Given this list of marker genes FKRP, AHNAK2, UNC5D, PLD3 (NCBI Gene Id 23646), GPR39, CCL1, CTDP1, SLC26A9, GBX2, ADGRL4, IL2RG, ZNF862, DEFA3, STRN4, ASXL3, LINC00242, PLEK, CD3D, GRTP1, POU4F2 (NCBI Gene Id 7894), PSMD2, TACR3, CSGALNACT1, OR5T1, TUSC1, AIM2, SPMIP5, GPR17, DNAJC28, KRTAP5-9, CD3G, DEFA1B, NLRP10, ZNF663P, DEFA1, TCP11, XKR6, here is a description of the gene set: studied in species Homo sapiens Human Gene Set: FIGUEROA_AML_METHYLATION_CLUSTER_6_DN from publication Figueroa ME, Lugthart S, Li Y, Erpelinck-Verschueren C, Deng X, Christos PJ, Schifano E, Booth J, van Putten W, Skrabanek L, Campagne F, Mazumdar M, Greally JM, Valk PJ, Löwenberg B, Delwel R, Melnick A (PMID 20060365) We hypothesized that DNA methylation distributes into specific patterns in cancer cells, which reflect critical biological differences. We therefore examined the methylation profiles of 344 patients with acute myeloid leukemia (AML). Clustering of these patients by methylation data segregated patients into 16 groups. Five of these groups defined new AML subtypes that shared no other known feature. In addition, DNA methylation profiles segregated patients with CEBPA aberrations from other subtypes of leukemia, defined four epigenetically distinct forms of AML with NPM1 mutations, and showed that established AML1-ETO, CBFb-MYH11, and PML-RARA leukemia entities are associated with specific methylation profiles. We report a 15 gene methylation classifier predictive of overall survival in an independent patient cohort (p < 0.001, adjusted for known covariates). Cluster 6 of aberrantly hypomethylated genes in blasts from AML (acute myeloid leukemia) patients.